The following is a description of a gene set: Mouse Gene Set: GOMF_16_HYDROXYPALMITATE_DEHYDROGENASE_ACTIVITY Catalysis of the reaction: 16-hydroxypalmitate + NADP = H+ + 16-oxo-palmitate + NADPH. studied in species Mus musculus, and this is the list of marker genes: Cyp4a12b, Cyp4a12a, Cyp4a29, Cyp4a30b, Cyp4a14